Given this list of marker genes Prkn, Fcgr2b, Hyou1, Tmbim6, App, here is a description of the gene set: The series of molecular signals in which an intracellular signal is conveyed to trigger the apoptotic death of a neuron. The pathway is induced in response to a stimulus indicating endoplasmic reticulum (ER) stress, and ends when the execution phase of apoptosis is triggered. ER stress usually results from the accumulation of unfolded or misfolded proteins in the ER lumen. Mouse Gene Set: GOBP_NEURON_INTRINSIC_APOPTOTIC_SIGNALING_PATHWAY_IN_RESPONSE_TO_ENDOPLASMIC_RETICULUM_STRESS studied in species Mus musculus